Given this list of marker genes TNRC6C, IGF2BP1, TOB1, CSDE1, CPEB3, TNRC6B, ZFP36L1, DHX9, AGO2, TENT4B, RC3H1, ZFP36L2, CNOT1, PAIP1, TENT4A, YBX1, PABPC1, DHX36, HNRNPU, CNOT7, ZFP36, HNRNPD, SYNCRIP, here is a description of the gene set: Human Gene Set: GOBP_REGULATION_OF_NUCLEAR_TRANSCRIBED_MRNA_CATABOLIC_PROCESS_DEADENYLATION_DEPENDENT_DECAY species: Homo sapiens Any process that modulates the frequency, rate or extent of nuclear-transcribed mRNA catabolic process, deadenylation-dependent decay.